Given this list of marker genes SLC25A17, SH3GL1, MANF, SF3B3, RBM4, ZDHHC9, NGEF, ZYX, ATF6B, SEC31A, PDIA6 (protein disulfide isomerase family A member 6), SEC23IP, STAB1, SNN, TRIM68, UGGT1, SAFB2, WDR19, ATXN7L3, RNASEH1, EDC4, TTLL11, HGS, MANSC1, ALOX12, POLR3E, POU4F1, HTATIP2, CARHSP1, MPG, PTTG1IP, LRRC17, PAQR4, P2RY10, EMP3, EPS8L2, CSTB, CERCAM, MAN2B1, CLEC1B, PYCARD, WDR13, FAM3B, ANKRD22, CASP8, C1QTNF2, RNF31, KCTD12, KHSRP, SLC29A3, GNB2, CENPW, EPHX3, COL4A2, CORO1A, LTO1, RIC8A, ITM2B, SMARCB1, SNRPG, GANAB, TMEM51, TCF7, PPT1, ADPRS, DCK, NCLN, MMP12, IL2RG, CA13, MAFB, CDK4, RAC3, EVL, PRIMPOL, PLBD1, MXD1, PHTF1, RRAGC, MTMR4, WDR38, ID2, ZNF7, MGAT2, KRT33A, DYNLL1, RNF166, CRELD2 (NCBI Gene Id 79174), PIP4K2C (phosphatidylinositol-5-phosphate 4-kinase type 2 gamma), EPB41L4A (NCBI Gene Id 64097), ATP8B2, TGFB1, DPM2, ERO1A, NIPAL4, TCF19, AR, SEMA4A, B2M, FAM171A1, IFNGR1, ARF5, KLF16 (NCBI Gene Id 83855), CD300C, PDK3, CMTM7, SNX18, CDR2, EDEM1, SLC7A6OS, SMARCAD1, ARPC3, CLCN7, IL6ST, MSN, RPS6KA6, PTPN9, PNPLA6, CHSY1, STRA6, FMO5, ENDOU, UNC50, YEATS2, TTLL12, AHSP, MYL12B, CENPA, CHADL, ZNF184, SIRPA, LY6E, OBI1, LPCAT3, BAX, IL10RB, ARHGDIB, KIRREL1 (kirre like nephrin family adhesion molecule 1), DBNL, EML2, UBE2Q1, CAD, NCBP1, CD68, RPL34 (ribosomal protein L34), PTHLH, GAK, EIF4A1, HVCN1, GPX8, BCAP31, AKT1, SLPI, FTL, VSTM4, SPTLC1, DERL2, MLX, ZMYND10, PCOLCE, IFITM2, LCN2, ARPIN, LAMA4, DSG1, C19orf48P, AGRP, SRPX2, ATOX1, IDNK, ST8SIA6, EP400, LCP2, LEPROT, GPX1, AKNA, HEBP2, SLC6A19, ACD, CD44, TMEM167B, PDIA3, NME3, CD300LG, ARPC4, PTPRA, LGMN, FAM43A, SLC46A3, NT5C2, FSCN1, ESYT1, ZNF236, MON2, COL23A1, SMAD1, PSMG3, IFNAR2, SGPL1, MFSD14B, here is a description of the gene set: studied in species Homo sapiens Murine Cytomegalovirus (MCMV) infection leads to early activation of various immune cells, including B and T lymphocytes, before the actual initiation of antigen-specific adaptive immunity. This activation is partly driven by innate cytokines, including type I interferon (IFN), which are induced early after infection. The objective of this study was to address the role of type I IFN in shaping early/innate B and T cell responses to a primary acute viral infection. In order to decipher the specific impact of IFN-I on cell subsets, we performed a genome-wide expression analysis on WT splenic B and CD8 T lymphocytes isolated from C57BL/6 mixed bone marrow chimera mice. This study complements series GSE39555, which focused on early responses of NK cells and of the two subsets of conventional dendritic cells. Human Gene Set: GSE45365_NK_CELL_VS_CD8A_DC_UP Genes up-regulated in NK cells versus CD8A T cells.